Given this list of marker genes Ippk (NCBI Gene Id 75678), Nudt11, Itpk1, Nudt10, Nudt3, Ip6k1, Ppip5k1, Nudt4, Ip6k3, Ppip5k2, here is a description of the gene set: Synthesis of pyrophosphates in the cytosol species: Mus musculus Mouse Gene Set: REACTOME_SYNTHESIS_OF_PYROPHOSPHATES_IN_THE_CYTOSOL